Given this list of marker genes PLXDC1, SLC44A1, MEGF10, DCN, TNFAIP8 (TNF alpha induced protein 8), GAS2L3, CYRIA, VCAM1, FGFR2, ZNF536, ARMH4, SENP8, RFLNA, CNTN1, APBB1, PAK1, SH3D19 (NCBI Gene Id 152503), ERRFI1, PDGFRA, ZBTB7C, COL23A1, here is a description of the gene set: Homeobox transcription factors are developmentally regulated genes that play crucial roles in tissue patterning. Homeobox C6 (HOXC6) is overexpressed in prostate cancers and correlated with cancer progression, but the downstream targets of HOXC6 are largely unknown. We have performed genome-wide localization analysis to identify promoters bound by HOXC6 in prostate cancer cells. This analysis identified 468 reproducibly bound promoters whose associated genes are involved in functions such as cell proliferation and apoptosis. We have complemented these data with expression profiling of prostates from mice with homozygous disruption of the Hoxc6 gene to identify 31 direct regulatory target genes of HOXC6. We show that HOXC6 directly regulates expression of bone morphogenic protein 7, fibroblast growth factor receptor 2, insulin-like growth factor binding protein 3, and platelet-derived growth factor receptor alpha (PDGFRA) in prostate cells and indirectly influences the Notch and Wnt signaling pathways in vivo. We further show that inhibition of PDGFRA reduces proliferation of prostate cancer cells, and that overexpression of HOXC6 can overcome the effects of PDGFRA inhibition. HOXC6 regulates genes with both oncogenic and tumor suppressor activities as well as several genes such as CD44 that are important for prostate branching morphogenesis and metastasis to the bone microenvironment. Human Gene Set: MCCABE_HOXC6_TARGETS_DN studied in species Homo sapiens from publication McCabe CD, Spyropoulos DD, Martin D, Moreno CS (PMID 18339881) Genes with promoters bound by HOXC6 in LNCaP cells (prostate cancer) and down-regulated upon loss of function (LOF) of HOXC6.